The following is a description of a gene set: studied in species Mus musculus Enables the directed movement of phosphatidylcholine into, out of or within a cell, or between cells. Phosphatidylcholine refers to a class of glycerophospholipids in which the phosphatidyl group is esterified to the hydroxyl group of choline. Mouse Gene Set: GOMF_PHOSPHATIDYLCHOLINE_TRANSPORTER_ACTIVITY, and this is the list of marker genes: Pitpnm2, Atp8b5, Abcb4, Abcb1a, Abca7, Abca1, Pitpna, Abca3, Atp10b, Pltp, Pctp, Pitpnm1, Scp2, Abcg1 (NCBI Gene Id 11307), Mttp, Pitpnb, Abcb1b, Atp8b2, Atp10a, Atp8b1